The following is a description of a gene set: Genes down-regulated in comparison of CD4 central memory T cells versus CD4 CXCR5+ T cells. Human Gene Set: GSE26928_CENTR_MEMORY_VS_CXCR5_POS_CD4_TCELL_DN from publication Chevalier N, Jarrossay D, Ho E, Avery DT, Ma CS, Yu D, Sallusto F, Tangye SG, Mackay CR (PMID 21471443) species: Homo sapiens, and this is the list of marker genes: MAPK1, LIMS1, ADGRA1, GEMIN4, UNC50, HGD, THUMPD3, FAM217B, TMEM176A, NSUN3, VPS41, GSTT4, CTBS, AGPAT3, QSER1, MAP3K4, SDCBP, FAM53C (NCBI Gene Id 51307), CHCHD4, MIR205HG, ENGASE, SUFU, FLOT1 (NCBI Gene Id 10211), HLA-DMB, MCUB (NCBI Gene Id 55013), VNN1, CSN1S2AP, ODF1, KLHL5 (NCBI Gene Id 54163), TMEM45B, SNN, DEF8, GPR26, SEC31B, CUX1, PAN3, GATD1, TLK1, HMHB1, NAB1, RBM43, OR10H3, SNX29, TUT7, NR1H3, PHRF1, AK3, NRIP1, GRAMD2A, ITPR1, KCNC4, ZFP42, ZNF141, EHHADH, KCNA6, ZMYM2, PLCD4, MC3R (melanocortin 3 receptor), BACH1, MARF1, TSPAN10, ZNF33B, PAXIP1, SDC1 (syndecan 1), TAS1R2, GARIN1A, SLC25A31, USF3, NKX2-1, ONECUT2, MAP3K8, RBM33, GARIN6, CYRIB, HPS4, SNX27, PRL, SFMBT2, ARHGEF11, KLK11, NT5DC1, WFIKKN2, ALOX15B, PRMT7, NME4, LINC00265, BAMBI, TAC1 (tachykinin precursor 1), SIGLEC16, BTBD19, ADAMTS9-AS2, FZD3, HOXA5, SNTB1, DNAJA4, GRIP2, CCSER1, TMEM254-AS1, YTHDC2, ZFAND5, CYP2A7, DDAH1, CFAP107, PLXND1, AMMECR1, GRHL2, AK5, PCP4, HAGHL, POF1B, S1PR3, FOXP1, PTBP2, C2CD3, SETD6 (NCBI Gene Id 79918), NINJ2-AS1, ADGRF3, DPH6, FASTKD5, GLCCI1, TMEM151B, TFCP2, GANC, BTAF1, RAD21, VENTXP1, TC2N, CDK14, CCDC93, GLS, SLC16A10, SLC9A8 (NCBI Gene Id 23315), CREB1, ARAP1, SENP2, TSTD2, TAF11, CYFIP2, GTF3C2, RETREG1, H2AC16, BAZ2B-AS1, CLEC4A, ERBIN, MDC1, CAMSAP1, CCNL1, DTWD1, SETDB1, YPEL5, ZSCAN23, ZNF225-AS1, DCDC2B, LINC00472, BANP, NPAS3, SUSD1, ASS1, TENT5A, OR9A1P, SBF2 (SET binding factor 2), ADAM22, PARS2 (NCBI Gene Id 91517), PTHLH, ATAD2, DLL1, ATP4A, GPR75, GID4, PUDP (pseudouridine 5'-phosphatase), MBOAT1, NTN5, KDM2A, LINC00652, CLEC5A, RBM17, LINC01096, LDLRAD4-AS1, MAP2K5, AGL, TCF7L2, TNFRSF10A-DT (NCBI Gene Id 389641), LANCL1, THAP2, MYH11, TBX10, PDZD9, GPRIN3, SSBP2, GNG7, KMO, TEX10 (testis expressed 10)